The following is a description of a gene set: Weakness of both lower extremities with sparing of the upper extremities. Paraplegia refers to a severe or complete loss of strength, whereas paraparesis refers to a relatively mild loss of strength. Human Gene Set: HP_PARAPLEGIA_PARAPARESIS species: Homo sapiens Paraplegia/paraparesis, and this is the list of marker genes: RILPL1, DAO, CARS1, AP4M1, RNASEH2C, PAX3, ANG, KPNA3, RASA1, ANXA11, NEK1 (NIMA related kinase 1), INTS8, SOX10, ATP6AP2, POLG, NEFH, ATP5F1D, IDUA, L1CAM, CAPN1, MT-ATP6, FGF8, UCHL1, PLP1, DDHD2, B3GALT6, CCT5, CYP7B1, TBCE, GAMT, MICOS13, AP4B1, HMBS, ARSI, SPG11, SP110, GBA1, SOD1, WDR45B, WDR48, DCC, ATP5MK, TNFRSF11A, TREX1, CFAP410, STXBP1, KIF5A, PEX16, PON2, NAGS, IBA57, SLC16A2, TBK1, KDM5C, SPAST, VPS37A, HPDL, FGFR1, SEMA3A, DDHD1, ATP5F1E, SELENOI, GLT8D1, MECP2, FLRT1, GOT2, SDHA, CHD7, MATR3, ALDH3A2 (aldehyde dehydrogenase 3 family member A2), PPP1R15B, SPTAN1, ATP5F1A, USP8, LRP12, POLR3GL, RAP1GDS1, NT5C2, ADGRG1, VAMP1, PRPS1, ATRX, ZFR (zinc finger RNA binding protein), ATXN2, GPT2, AP5Z1, TECPR2, REEP1, RNU7-1, SLC25A15, CCDC88C, MPLKIP, AIMP1, ASCC3, VCP, SLC19A3, CPT1C, ABCA12, DSTYK, PFN1, HS6ST1, GBA2, TARS1 (NCBI Gene Id 94887), PRPH, SQSTM1, CKAP2L, IFIH1, ERCC2, ARL6IP1, DCTN1, TREM2, FARS2, BSCL2, RNASEH2A, LAMB1, SETX, TFG, OPA1, ASAH1, FEZF1, MARS1, KIF1A, TTC19, ERLIN2, CHCHD10, FA2H, CCDC141, ATPAF2, PGAP1, SLC30A10, ENTPD1, ERCC3, C9orf72, SPG21, MED13L (mediator complex subunit 13L), ATP13A2, LYST, RNF113A, RTN2, PROK2, NDNF, HSPD1, KY (NCBI Gene Id 339855), RNF170, NF1, TOE1, CYP2U1, HACE1, PROKR2, SDHAF1, CCNF, ELOVL1, SDHD, TRMT10A, FLRT3, PAH, AARS1, ATL1, FGF17, GBE1, SDHB, PNP, VAPB, NIPA1, KIDINS220, MTPAP, PON1, ERBB4, ARG1, GFAP, PPARGC1A, DUSP6, SPART, GTF2H5, SAMD9, B4GALNT1, MAG, COASY, AIFM1, HESX1, RNF220, FIG4, GAN, BTD, ALDH18A1, WDR45, ATP5MC3, FUS, WASHC5, ABHD16A, HNRNPA1, NFU1, CLTC, FAR1, UBQLN2, TTR, MTRFR, PDHX, LSM11, RNASEH2B, ANOS1, AFG3L2, SPRY4, PON3, GTF2E2, CHMP2B, AP4S1, GIPC1, ABCD1, TACR3, ADAR, SLC33A1, CYP27A1, RAB3GAP2, MT-ATP8, NOTCH2NLC, TARDBP, PRUNE1, GJC2 (NCBI Gene Id 57165), UNC13A, GJB1, REEP2, UBAP1, EDNRB, SRPX2 (NCBI Gene Id 27286), PEX3, AP4E1, SAMHD1, OPA3, SLC2A1, MTHFR, WDR11, BCOR, IL17RD, ALS2, AMPD2, GLE1, KLC2, OPTN, TAF15, GALC, CACNA1D, DNM1L, PNPLA6, SPG7, ZFYVE26, GJA1, AMFR, PI4KA, MAN2B1, C19orf12